The following is a description of a gene set: Mouse Gene Set: GOBP_RESPONSE_TO_ALCOHOL Any process that results in a change in state or activity of a cell or an organism (in terms of movement, secretion, enzyme production, gene expression, etc.) as a result of an alcohol stimulus. species: Mus musculus, and this is the list of marker genes: Foxo3, Shh, Stk39 (serine/threonine kinase 39), Adcy8, Tacr1, Gramd1b, Drd2, Hmgcs2, Abca1, Gata3, Ces1b, Il2, Kcnmb1, Ctsk, Npas4, Drd3, Cbl, Tgfbr2, Ucp1, Adh7 (NCBI Gene Id 99597), Fancb, Ptger3, Actc1, Recql5, Gnai1, Ccr7 (C-C motif chemokine receptor 7), Adh1, Hdac8, St6gal1, Sfrp1, Klf9, F7, Scnn1g, Cpt1a, Eif4g1, Fech, Zfp212, Avp, Ggt1, G6pdx, Ccl3, Pten, Gabbr1, Nefl, Rpl27, Grin3a, Serpina1b, Pck1, Polb, Penk, Slc12a3, Creb1, Gria1, Ccl19-ps3, Osbpl7, Birc2, Blm, Ppara, Ccl19-ps5, A2m (NCBI Gene Id 232345), Ptgdr, Gk, Abcb11, Aanat, Avpr1a, Bcl2, Nppc, Lancl2, Hnrnpd, Ptger1, Srebf1, Card9, Th, Fgf2, Abcb1a, Mir145a, Gpr155, Elk1 (NCBI Gene Id 13712), Rps6, Borcs7, Ccl7, Fgf15, Dynapl1, Foxp3, Tgfbr1, Myd88, Ogg1, Cftr, Gnrh1, Dmap1, Ccl21a, Ehmt2, Ccl21f, Ccl2, Inhbb, Ptger4, Grip1, Dynap, Prkce, Htr1b, Cat, Csf3, Pf4, mt-Cytb, Ccl19-ps4, Acaca, Ggh, Adipor2, Dag1, Tnf, Larp1, Sod1, Hcrt, Trh, Aldh1a1, Cnr1, Adcy1, Adcyap1, Prkd1 (NCBI Gene Id 18760), Unc79, Lipa, Btg2, Cyp27b1, Ptger2, Nanog, Scnn1b, Adal, Casp8, Ptgfr, Serpina1a, Ctnna1, Adcy3, Ces1g, Serpina1d, Mir339, Nr0b2, Prkcb, Smo, Arc, Agtr1a, Ccl19-ps1, Prkaa1, Star, Inhba, Rps6kb1, Ghr, Nlrp3, Ccl19-ps6 (C-C motif chemokine ligand 19, pseudogene 6), Comt, Tlr4, Slc23a2, Itpr2, Grin2b, Slc5a5, Slc10a1, Ahr, Nqo1, Chrna7, Lep, Tnfsf4, Apobec1, Rela, Adcy6, Prkaa2, Gramd1c, Mir30a, Cldn3, Trp53inp1, Mlc1, Ccr5, Ireb2, Epha5, Mir29c, Hrh3, Dbh, Nfe2l1, Mir30e, Mdm2, Fkbp5, Slc6a3, Setd7, Usp46, Rplp0, Cdkn1a, Efna5 (ephrin A5), Cyp7a1, Oxt, Alad, Sirt1, Tnfrsf11a, Lrp6, Ugt1a1, Slc2a4, Chrnb2, Glra2, Pmvk, Ace (NCBI Gene Id 11421), Akt1, Tjp1, Mir296, Ces1e, Maob, Glb1, Ccl21e, Tbxas1, Gstp1, Cldn18, Ces1a, Adcy2, Hoxa1, Fbp1, Ctnnb1, Got2, Sphk2, Adcy5, Bcl2l1, Gramd1a, Fyn, Cldn5, Glra3, Grin2a, Crh, Mir9-1, Mir152, Tspo, Ucn3 (urocortin 3), Gkn2, Ppp1r9b, Mir200a, Klf4, Hspa8, Phb1, Lct, Htr7, P2ry6, Klf2 (NCBI Gene Id 16598), Brca1, Hpgd, Ccl21d, Sod2, Cdk4, Oprd1, Igf1 (NCBI Gene Id 320499), Aldh2, Adcy7, Cyp1b1, Mir10a, Mir154, Eef1b2, Aacs, Fkrp, Cdk1, Mir362, Hdac6, Ccl21b, Ccl19, Fosb, Hnf1a, G6pd2, Psmd14, Glra1, Golph3, Rgs2, Map4k1, mt-Nd4, Ces1d, Fosl1, Ces1f, Cda, Crhbp, Scn11a, Spidr, Lrp8, Mir9-2, Slit3, Cybb, Crhr1, Igf1r, Arsa, Oprm1, Eps8, Akr1c18, Hnrnpk, Sgk1, Gpld1, Arpc2, Rara, Cdh1, Rps6-ps4, Tbxa2r, Nr3c2, Cldn1, Ptch1 (patched 1), Aifm1, Adipoq, Kcnc2, Pax6, Ces1c, Jup, Adra2a, Adam15, Tufm, Fdx1, Fos, Cd14 (NCBI Gene Id 12475), Mir9-3, Sdf4, Tnc, Cldn7, Ifitm5, Abat, Serpina1e, Mir10b, Tgfbr3, Ncam1 (neural cell adhesion molecule 1), Smad2, Dnmt3a, Mir496a, Csn1s1, Cdo1, Gnas, Prkca, Ces1h, Bak1, Serpina1c, Mecp2, Asns, Tgfb1, Tyms, Scnn1a (NCBI Gene Id 20276), Grin1, Mstn, Vhl (NCBI Gene Id 22346), Atp5f1a, P2ry4, Cad, Akap8, Ptk2b, Nr3c1, Rad51